The following is a description of a gene set: Splicing of RNA via a series of two transesterification reactions. Human Gene Set: GOBP_RNA_SPLICING_VIA_TRANSESTERIFICATION_REACTIONS studied in species Homo sapiens, and this is the list of marker genes: HNRNPR, RNVU1-3, SNRPD2, AAR2, RBM4, CELF1, EIF4A3, SFPQ, CTNNBL1, SRSF6, SF3A1, U2AF1L4, RNU5F-1, LSM2, NSRP1, CD2BP2, PSIP1, RBM41, RBM23, DHX16, PRPF8, SNRNP35, ESRP2, CWC25, IK, SRSF4, DDX1, RNPS1, DHX35 (NCBI Gene Id 60625), SLC39A5, HNRNPUL2, GPKOW, RBMXL2 (RBMX like 2), THUMPD2, RNU4-1, RBM47, HNRNPK, CACTIN, STH, METTL16, TIA1, ZMAT2, FRG1, RBM15, CELF4, ISY1, PLRG1, SART3, PRPF3, SF3B5, CWC27, HNRNPU, SNRNP27, RNU11, SMU1, HTATSF1, YTHDC1, GEMIN5, SRSF1, METTL3, YJU2B, KHDRBS3, HNRNPA3, SDE2, ACIN1, HNRNPC, SMNDC1, SCAF11, REST, RBMX2, SART1, GCFC2, PRPF40A (pre-mRNA processing factor 40 homolog A), DBR1, LUC7L2, PRPF31, CDK13, RNU4ATAC, HNRNPUL1, U2AF1, SF3A3, SF3B1, BUD13, GPATCH8, PRPF40B, SRRM2, UBL5, SYF2, RNVU1-1, U2AF2, DDX46, WBP4, WEE2-AS1, NCBP1, CWF19L1, NCL, TRA2B, SNRPN, MYOD1, NOVA1, DAZAP1, RBM15B, RNU5A-1, RBM11, PRPF38A, SRSF2, RNU5B-1, METTL14, RBMY1J, CLNS1A, DDX39A, SFSWAP, NCBP2, LSM4 (LSM4 homolog, U6 small nuclear RNA and mRNA degradation associated), EFTUD2, BUD31, HNRNPA2B1, HNRNPA1, COIL, DDX5, RBM22, RBPMS2, RNVU1-6, SLU7, SF3B6 (NCBI Gene Id 51639), PPIL1, ZRSR2P1, CWC15, PRPF4, TGS1, LUC7L, GEMIN6, ILF3, CASC3 (NCBI Gene Id 22794), SRRM4, CENATAC, KHSRP (KH-type splicing regulatory protein), HNRNPM, SRSF5, DCPS, WTAP, SNW1, HNRNPL, CDC5L, SNRNP25, PCBP4, SNRPD1, PTBP2, SRSF12, RBM7, RBMY1E, GEMIN4, SNRPB, SRSF9, RBFOX2, NCBP2L, SNRPC, JMJD6, USP49, GEMIN8, RBFOX1, RNU6-1, MTREX, GPATCH1, PQBP1 (polyglutamine binding protein 1), HSPA8, ARB2A, RBMXL1, RNVU1-7, SNRNP200, ZC3H14, SNRPGP15, HNRNPA1L3, FMR1, DHX40, RNU4-2, CRNKL1, RBMY1D, SRSF3, UPF1, RBMY1A1, SRPK2, KHDRBS2, RNVU1-17, RNVU1-4, DHX8, SNRNP70, TXNL4A, RBFOX3 (RNA binding fox-1 homolog 3), ZBTB7A, DDX41, DHX38, USP39, KHDC4, NOL3, CIRBP, FRA10AC1, PNN, SF1, SNRPE, NPM1, ZRSR2, PAXBP1, SF3B3, RBM39, LSM5, SNU13, PRP4K, DHX9, TRA2A, RNVU1-8, ZCCHC8, SF3A2, RBMY1F, PABPC1, HMX2, EXOSC10 (exosome component 10), PHF5A, RNU1-4, PPIL3, MFAP1, NOVA2, SF3B4, RNU2-1, LSM3, RBM25, RBM20, RSRC1, RNVU1-15, GEMIN7 (gem nuclear organelle associated protein 7), RNPC3, RBM10, PPIH, ARGLU1, THRAP3, RBMX, RBM8A, RBM3, SRPK1, CWF19L2, RALY, INTS15, PRPF6, SRSF10, SETX, XAB2, SNRPD3, SCNM1, RBPMS, KHDRBS1, LSM7, RNVU1-14, DHX15, HNRNPH1, CELF5, UPF3A, LSM1, SAP18, AQR, SRSF7, BCAS2, WDR77, CELF2, SNRPF, RBM6, DDX23, NUP98, MAGOHB, RBM44, LSM8, CDC40, QKI, RNU6-7, DNAJC17, RBM5, DDX17, SRSF8, CELF3, CELF6, RNVU1-19, TAF12-DT (NCBI Gene Id 105378616), PRPF39 (NCBI Gene Id 81951), SRPK3, LUC7L3, UPF3B, ZCRB1, C9orf78, SNRPG, PRPF18, PPWD1, SNIP1, RNU6-9, RNU5E-1, RBMXL3, PTBP1, PPIE, HNRNPA1L2, RNF113A (ring finger protein 113A), RNVU1-2A, STRAP, TXNL4B, HNRNPH3, PRPF19, PRMT7, RSRP1, USP4, TSSC4, FBXO24, C1QBP, RBM14, RBMY1B, SON, SRRM1, WDR83, SNRPA1, SNRPA, MPHOSPH10, SMN1, RBM24, SNRNP40, DDX42, SNRPB2, TFIP11, HNRNPF, LARP7, PUF60, RBM17, SMN2, LSM6, SYNCRIP, CWC22, RNU5D-1, SF3B2, PRDX6, RNU6ATAC, DDX20, MAGOH, YJU2, ESS2, RBM42, DYRK1A (dual specificity tyrosine phosphorylation regulated kinase 1A), DDX39B, GEMIN2, PRMT5